The following is a description of a gene set: species: Mus musculus from publication Guillaumond F, Gréchez-Cassiau A, Subramaniam M, Brangolo S, Peteri-Brünback B, Staels B, Fiévet C, Spelsberg TC, Delaunay F, Teboul M (PMID 20385766) The circadian timing system coordinates many aspects of mammalian physiology and behavior in synchrony with the external light/dark cycle. These rhythms are driven by endogenous molecular clocks present in most body cells. Many clock outputs are transcriptional regulators, suggesting that clock genes primarily control physiology through indirect pathways. Here, we show that Krüppel-like factor 10 (KLF10) displays a robust circadian expression pattern in wild-type mouse liver but not in clock-deficient Bmal1 knockout mice. Consistently, the Klf10 promoter recruited the BMAL1 core clock protein and was transactivated by the CLOCK-BMAL1 heterodimer through a conserved E-box response element. Profiling the liver transcriptome from Klf10(-/-) mice identified 158 regulated genes with significant enrichment for transcripts involved in lipid and carbohydrate metabolism. Importantly, approximately 56% of these metabolic genes are clock controlled. Male Klf10(-/-) mice displayed postprandial and fasting hyperglycemia, a phenotype accompanied by a significant time-of-day-dependent upregulation of the gluconeogenic gene Pepck and increased hepatic glucose production. Consistently, functional data showed that the proximal Pepck promoter is repressed directly by KLF10. Klf10(-/-) females were normoglycemic but displayed higher plasma triglycerides. Correspondingly, rhythmic gene expression of components of the lipogenic pathway, including Srebp1c, Fas, and Elovl6, was altered in females. Collectively, these data establish KLF10 as a required circadian transcriptional regulator that links the molecular clock to energy metabolism in the liver. Mouse Gene Set: GUILLAUMOND_KLF10_TARGETS_DN Genes down-regulated in the liver tissue from 10 week old male mice with KLF10 compared to wild-type littermates., and this is the list of marker genes: Slco1b2, Ak3 (adenylate kinase 3), Srsf3, Enpep, Aqp9, Ugt3a2, Ostc, Rtn4, Ogt, Cyb5r3, Ctnnb1 (NCBI Gene Id 12387), Rpl7l1, Ctss, Gpd1, Rcan1, Aacs, Txnip, Sec61a1, Fcna, Derl2, Vnn1, Vmp1, Tmsb4x, Chpt1, Elovl5, Clec4f (NCBI Gene Id 97335), Cd36, Slc2a2 (NCBI Gene Id 99576), Papss2, Psme4, Oit3